The following is a description of a gene set: Human Gene Set: HP_SEPTO_OPTIC_DYSPLASIA Septo-optic dysplasia Underdevelopment of the optic nerve and absence of the septum pellucidum. studied in species Homo sapiens, and this is the list of marker genes: STAG2, ROBO1, PROKR2, HESX1, SOX2, WDR11, PROP1, FOXA2, GLI2, LHX4, CDON, FGFR1, GPR161, SOX3, TBX4, RSPO2, WNT3, POU1F1, CDC42BPB, OTX2, ARNT2